The following is a description of a gene set: species: Homo sapiens Acute infectious pneumonia Acute inflammation of the lung due to an infection. Human Gene Set: HP_ACUTE_INFECTIOUS_PNEUMONIA, and this is the list of marker genes: CSF2RA, SCNN1A, SCNN1G, CSF2RB, CFTR, SCNN1B